The following is a description of a gene set: studied in species Homo sapiens Reactome Pathway: Association of TriC/CCT with target proteins during biosynthesis TRiC has broad recognition specificities, but in the cell it interacts with only a defined set of substrates. Many of its substrates that are targeted during biosynthesis are conserved between mammals and yeast. part of: Chaperonin-mediated protein folding, and this is the list of marker genes: CCT5, FBXW10, CCT8, FBXW5, USP11, KIF13A, AP3M1, FBXW9, CCNE2, CCT6B, FBXO6 (F-box protein 6), FBXL5, FKBP9, FBXW7, GBA1, HDAC3, TCP1, STAT3, CCT6A, FBXW4, LONP2, CCT7, FBXW2, SPHK1 (sphingosine kinase 1), GAPDHS, FBXO4, CCT2, CCT3, NOP56, WRAP53 (WD repeat containing antisense to TP53), CCNE1, XRN2, DCAF7, FBXL3, KIFC3, SKIC2, TP53, CCT4, ARFGEF2